The following is a description of a gene set: species: Mus musculus Mouse Gene Set: REACTOME_GLYOXYLATE_METABOLISM_AND_GLYCINE_DEGRADATION Glyoxylate metabolism and glycine degradation, and this is the list of marker genes: Dao, Gnmt, Prodh2, Grhpr, Ogdh, Hao1, Agxt, Dld, Gcsh (NCBI Gene Id 68413), Ddo, Aldh4a1 (NCBI Gene Id 277810), Gldc, Dlst, Agxt2, Mrps36, Hoga1, Got2, Amt